The following is a description of a gene set: Mouse Gene Set: REACTOME_RND1_GTPASE_CYCLE RND1 GTPase cycle species: Mus musculus, and this is the list of marker genes: Pik3r1, Depdc1b, Rasal2 (NCBI Gene Id 320357, RAS protein activator like 2), Txnl1, Vangl1, Frs2, Cpd, Pkp4, Stmn2, Ankrd26, Wdr6 (NCBI Gene Id 83669), Grb7, Ptpn13, Fam83b, Frs3, Kif14, Muc13, Stip1, Aldh3a2, Vangl2, Epha2, Arhgap5, Dst, Flot2, Cav1, Pik3r2, Epsti1 (epithelial stromal interaction 1), Kidins220, Tfrc, Fam135a, Plxna1, Dlg5, Ubxn11, Plekhg5, Arhgap35, Rnd1, Ccdc88a, Rras2, Rbm39, Tmem59, Dsp, Rbmx